The following is a description of a gene set: Binds to and increases the activity of a ubiquitin-protein transferase. species: Homo sapiens Human Gene Set: GOMF_UBIQUITIN_PROTEIN_TRANSFERASE_ACTIVATOR_ACTIVITY, and this is the list of marker genes: UBE2L3, PIN1, TRIB3, PTEN, CDKN1B, PEX12, CDC20B (cell division cycle 20B), CBX8, CDC20, RING1, BTRC, ENTREP1, FBXW7, UBE2N, FZR1, RBCK1, BMI1